The following is a description of a gene set: mouse primary BMDCs were stimulated with tlr ligands and gene expression changes were profiled on Affymetrix arrays Genes up-regulated in comparison of dendritic cells (DC) stimulated with LPS (TLR4 agonist) at 12 h versus DC cells stimulated with poly(I:C) (TLR3 agonist) at 12 h. Human Gene Set: GSE17721_LPS_VS_POLYIC_12H_BMDC_UP species: Homo sapiens from publication Amit I, Garber M, Chevrier N, Leite AP, Donner Y, Eisenhaure T, Guttman M, Grenier JK, Li W, Zuk O, Schubert LA, Birditt B, Shay T, Goren A, Zhang X, Smith Z, Deering R, McDonald RC, Cabili M, Bernstein BE, Rinn JL, Meissner A, Root DE, Hacohen N, Regev A (PMID 19729616), and this is the list of marker genes: IER5, MPHOSPH8 (M-phase phosphoprotein 8), FOXJ3, FAM20B, PRRX1, ICOSLG, CRYGS, TAF13, EPRS1, VDAC3, NCBP2, ECHS1, UTP20, EIF4G2, ABT1, USP24, NOP14, TRAF1, HS6ST1, CTBS, SEPHS2, TPRKB, ECD, SMPDL3B, PABIR1, NUP160, JAG1, CRY1, SMIM7, RETREG2, SPTSSB, ITSN1, SEC31A, TIMM10B, GLMN, TRMT112, NUP62, AKR1D1, ADAM17, NADK, ST3GAL1, PPTC7, NOP16, HEATR6 (NCBI Gene Id 63897), ADORA2B, UBLCP1, NUCKS1, UTP25, NOL11, PAFAH1B1, POLR2A, FDFT1, OTUD4 (NCBI Gene Id 95936), NUP50, PWP1, KRT12, ABHD17C, PHF8, USP21, TMCO1, MYDGF, MCM3, FMNL3, RCC1L, CSF1, IGFBP4, SACM1L (NCBI Gene Id 22908), GPN1, LPP, PTGR1, RNF126, IVNS1ABP, IFRD2, GNL3, MPG, ITGAX, SRSF1, ANP32A (acidic nuclear phosphoprotein 32 family member A), IRF4, TMEM63B, FN1, NOC2L, MTF2, TM9SF4, CHADL, PDE4B, SPRYD4, TRIM21 (tripartite motif containing 21), GDI1, COMMD7, CYFIP2, COX6C, ACLY, CAND1, M1AP, HSPA4, AKR1B15, PDLIM7, MIEN1, SRM, TMEM39A, ST3GAL5, CSDE1, PTCD2, RRN3, CSAD, LRRC59, NUTF2, MECR, NCBP1, HSD3B7, USP34, DNAJB6, ERI3, MTG1, ASRGL1, SLC18A3, LRRC14, MOGS, TRAF3IP2, ZFP82, SLC41A2, PTX3, SPEN, DDB1, ZFP64, AP3S1, CTU1, SERPINE1, AIFM1, IGF2R, BOLA1, ARHGAP24, CHCHD2, PON2, HCN2, TMEM135, DYM, ZBTB1, STT3A, BDH1, JAK2, DGAT2, NEK9, ATG7, PNO1, PSMD12, CNOT3, HADHB, NOTCH3, ZDHHC3, DAB2IP, PRMT1, STARD4, GSTM1, EPS15L1, PDF, PILRA, NAA30, PES1, MSANTD4, PSMD6, GHDC, RHOA, PPT2, SLC6A12, UHMK1, GCLC, CLCC1, IFITM10, MAP3K11, SLC20A1, AOAH, TRIM27 (tripartite motif containing 27), RIOK2, G6PD, NOA1, NFKBIB, SMAD7, CAT, GAS2, GSS, ARL1, NFATC3, CDR2, CTBP2, CDC25A (NCBI Gene Id 993), RNF26, MRPS12, TAGLN2, TIMM17B, PCNX1, PINX1, PRMT3, PMPCA, XPO7, CHID1, F13B, SUOX, CEP104